Given this list of marker genes Usp34 (NCBI Gene Id 636561), Irf6, Kif13a, Bri3bp, Zbtb14, Rpl17, Gdnf, Gtf2e1, Otud7b, Kcnk2, Rex2 (reduced expression 2), Skil, Rgs8, Npc1, Itga9, Ankrd13a, Vasn, Rdh16, Smg7, Tacr3, Esr1, Drp2, Zfp981, Htr2c, Kbtbd8, Fam53c, Gclm, Fut9, Ston2, Trmt9b, Nfe2, Homer2, Sult1c2, Taf7l, Vezf1, Rdx, Rasa3, Erlec1, Setd7, Rdh9, Camk4, Ppp1r12a, Zfp600, Zfp711, Mecp2, Slc9a6, Mtx3, Gata3 (NCBI Gene Id 14462), Capza2, Kcnh8, Slc25a36, Zfc3h1, Cnksr2, Zfp980, Yes1, Zbtb39, Rab12, Fgd4, Pole, Bace1, Zmym3, Ptbp2, Gtf2h1, Parpbp, Bcl2l11, Hip1, Siah1a, Alg11, Wnt9a, Ptges3, Crat, Mindy2, Camk1d, Camta1, Igsf10, Rfx3, Rbm39, Cab39, Zfp827, Retnlb, Lrrtm2, Lgals1 (lectin, galactose binding, soluble 1), Prdm15, Ipmk, Cyrib, Orai2, Plppr2, Pnisr, Mettl21e, Clp1, Art4, Nr4a2, Tmem258, Phactr2, Pwwp2a, Stim2, Esrrg, Galnt6, Trpa1, Wdhd1, Nav1, Parg, Dctn3, Dap3, Ankrd6, Rab37, here is a description of the gene set: Mouse Gene Set: MIR_9768_3P from publication Chen Y, Wang X (PMID 31504780) Genes predicted to be targets of miRBase v22 microRNA mmu_miR_9768_3p in miRDB v6.0 with MirTarget v4 prediction scores > 80 (high confidence targets). species: Mus musculus